Given this list of marker genes Trp53inp2, Slc20a1, Gabarap, Birc3, Ddit3, Stc1 (NCBI Gene Id 20855), Ddx5, Krt23, Ptpn1 (protein tyrosine phosphatase, non-receptor type 1), Avpi1, Plat, Elp5, Myl9, Pde4b, Azin1, Atf3, Il6, Dnajb6, Tbc1d32, Brd2, Kpna1, Sub1 (SUB1 homolog, transcriptional regulator), Ch25h, Pcna, Tgfb3, Cd36, Sfn (stratifin), Ndel1, Rnd1, Birc2, Jund (NCBI Gene Id 16478), Rbm18, Srsf3, Krt8, Ppp2r2a, Nol10, Ppig, Pim1, Sdc4, Igfbp5, Ier5, Mt2, Calm2, Sting1, Tpm2 (tropomyosin 2, beta), Insig2, Chmp4b, Samd4, Sema4c, Zfp703, Slc3a2, Tspan12, Vps37b, Chchd2, Noct, Sat1, Fabp4, Ets2, Errfi1, Pnrc1, Fosl2, Mfge8, Oat, Eef1a1, Lzts2, Uap1, Cyp1b1, Trip10, Camk2g, Naf1, Tagln, Eef2, Vcf1, Fgl2, Nectin2, Synpo, Tmed5, Sar1a, Nherf1, Rpl14, Ppard, Zfp131, Stk40, Mafg, Pnp, Tifa, Mat2a (methionine adenosyltransferase 2A), Txnrd1, Ralgds, Klhl7, Lrrc32, Rheb, Sbds, Pxdc1, Lcmt2, Cdk11b, Tgoln1 (trans-golgi network protein), S1pr3, Bcr, Stk19, Eif4a1, Eprs1, Cpe, Hspa9, Pim3, Usp37, Slc25a25 (solute carrier family 25 (mitochondrial carrier, phosphate carrier), member 25), Hipk3, Areg, Relb, Vdac1, Nr4a1, Gsto1, Sap18, Rgs16, Krt18, Klhl21, Hif1a, Srxn1, Smarca5, Ninj1, Rusc1, Eif5, Cnn1, Zfp994, Synpo2, Chka, Rplp1, Cstb, Rbm3, Gsta4, Tor1aip1, Inpp5a, Adamts4, Tpt1, Impdh2, Hspa2, Rab6a, Siah2, Tpi1, Lgals3, Sncg, Map1lc3b, Map2k3, Eif1a, Rhoc, Jmjd1c, Cdc42ep4, Fgf1, Dnajb9, Ftl1, Btg1, Kctd10, Fas, Arrdc3, Ppp1cb, Pgm1, Top1, Rassf1, Stat3, Dmpk, Nfe2l2, Dstn, Zfp706, Col14a1, Map3k20, Ly6d, Tmem241, Gapdh, Tubb6, Mustn1 (musculoskeletal, embryonic nuclear protein 1), Fem1b, Sbno2, Rpl12, Nop58, Hilpda, Ccn3, Akap12, Rela, Atxn7l1, Lmo4, Thrb, Txnl1, Efhd2, Arid5a, Spag9, Dot1l, Cebpb, Ivl, Abt1, Csrp1, Chp1, Odc1, Zfp287, Ptgs2, Xdh, Atp5f1d, Myh11, Med31, Rasl11a, Flna, Rnase4, Apold1, Actn1, Sox7, Pxn, Aldoa, Tsc22d2, Ube2s, Bcl2l13, Gadd45b, Eif2s2 (NCBI Gene Id 99435), Ell2, Thoc6, Snhg1, Tob2, Dnaja1, Synm, Junb, Bag3, Pdlim1, Rhoq, Fbxo33, Slc16a3, Ccnl1 (NCBI Gene Id 99790), Niban1, Foxc1, Casp4, Aldh2, Serpine2, Tuba1c (tubulin, alpha 1C), Hspa5, Rcan1, Eif1, Bcl3, Sorbs1, Procr (NCBI Gene Id 98921), 4930523C07Rik, Ier3 (NCBI Gene Id 15937), Nrip3, Midn, Lmna, Ndufb2, Exo5, Pcnp (PEST proteolytic signal containing nuclear protein), Tpm3, Cwc25, Fhl1, Isg20l2, Usp2, Ppp1r2, Hk2, Snu13, Plac9, Hdlbp, Itpk1, Pbxip1 (NCBI Gene Id 229534), Vegfa, Sirt1, Tm2d2, Stk11, Etf1, Emd, Ethe1, Ythdc1, Maff, Oga, Spty2d1, Kcnmb1, Trib1, Fxyd1, Cdkn1a, Snhg12, Sqstm1, Rpl21, Gpx4, Arpc3, Cald1, Zfand5, Rsrp1, Crip1, Ddx3x, Rps2, Ccnd3, Mepce, Rbm7, Hmox1, U2af1, Eif5a, Emp1, Ugdh, Pmvk, Stk38l, Arf4, Plcd1, Fbl, Nfil3, Rpl4, Hsp90aa1, Map1b, Tuba4a, Ywhaz, Rpl23a, Ndufs2, Vim, Gpr146, Ngf, Gbp4, Wsb1, Ppp1r14a, Irs2 (insulin receptor substrate 2), Mt1, Ccdc107, Arih1, Dgat1, Itga8, Kcnab1, Cenpj, Crispld2, Oxnad1, Gcnt1, Ifrd1, Mzt2, Nr4a2, Gstt1, Rrad, Tubb2a, H2-Eb1, Eloc, Timp4, Hsph1, Dad1, Csnk1d, Bltp1, Gja1, Gem, Zfand2a, Gla, Ubc, Fosl1, Gm13889, H2bc4, Mafk, Tomm20, S100a6, Tmem123, Mcl1, Zfp655, Upp1, Eif6, Slc66a2, Csrnp1, Thbs1, Srsf7, Mapkapk2, Trmt61b, Rabgef1, Rhpn2, Clic4, Igtp, 2410006H16Rik, Crem (cAMP responsive element modulator), Utp4, Dnaaf10, Ckb, Rap1b, Nars1, Nolc1, Hbegf, Snhg15, Wfdc2, Cbarp, Txndc11, Rell1, Chic2, Atf4, Kdm6b, Rnf4, Cltb, Fth1, Pvr, Gdf15, Sprr1a, Pkm, Nop14, Vmp1, Tubb4b, Litaf, Adamts1, Map1lc3a, Tnfrsf12a, Slc38a2, Tlnrd1, H3f3b, Ppp1r15a, Rps12, Ppp2ca, Gstm1, Gna13, Cebpd, Mylk, Rrm1 (ribonucleotide reductase M1), Acta2, Pafah1b1, Tiparp, Ube2d3, Gpr4, Isca1, Atp5mk, here is a description of the gene set: from publication Tabula Muris Consortium (PMID 32669714) Mouse Gene Set: TABULA_MURIS_SENIS_BLADDER_ENDOTHELIAL_CELL_AGEING studied in species Mus musculus